The following is a description of a gene set: from publication Kennedy RB, Oberg AL, Ovsyannikova IG, Haralambieva IH, Grill D, Poland GA (PMID 23594957) Human Gene Set: KENNEDY_PBMC_DRYVAX_AGE_18_50YO_STIMULATED_VS_UNSTIMULATED_1_TO_48MO_TOP_DEG_UP species: Homo sapiens Genes up-regulated in peripheral blood mononuclear cell stimulated vs unstimulated in adults (18-40) after exposure to Dryvax, time point 1 to 48M. Comment: top differentially expressed genes, more avail in Suppl Materials Despite its eradication over 30 years ago, smallpox (as well as other orthopox viruses) remains a pathogen of interest both in terms of biodefense and for its use as a vector for vaccines and immunotherapies. Here we describe the application of mRNA-Seq transcriptome profiling to understanding immune responses in smallpox vaccine recipients. Contrary to other studies examining gene expression in virally infected cell lines, we utilized a mixed population of peripheral blood mononuclear cells in order to capture the essential intercellular interactions that occur in vivo, and would otherwise be lost, using single cell lines or isolated primary cell subsets. In this mixed cell population we were able to detect expression of all annotated vaccinia genes. On the host side, a number of genes encoding cytokines, chemokines, complement factors and intracellular signaling molecules were downregulated upon viral infection, whereas genes encoding histone proteins and the interferon response were upregulated. We also identified a small number of genes that exhibited significantly different expression profiles in subjects with robust humoral immunity compared with those with weaker humoral responses. Our results provide evidence that differential gene regulation patterns may be at work in individuals with robust humoral immunity compared with those with weaker humoral immune responses., and this is the list of marker genes: H1-3, IFNG, H2AC17, HSPA6 (heat shock protein family A (Hsp70) member 6), LVRN, H4C16, H2BC15, H4C5, H4C3, H4C8, H2AC20, H2BC8, RNF152, H1-4, IFNB1, CH25H, WFIKKN1, IL3, HSPA4L, H2AC8, EPHB3, TNFRSF10D